The following is a description of a gene set: The genome of vertebrates contains endogenous retroviruses (ERVs) that have resulted from ancestral infections by exogenous retroviruses. ERVs are germline encoded, transmitted in a Mendelian fashion and account for about 8% of the human and 9.9% of the murine genome, respectively1, 2. By spontaneous activation and reintegration ERVs may cause insertional mutagenesis and thus participate in the process of malignant transformation or progression of tumor growth3, 4. However, if the innate immune system is able to recognize and control ERVs has not yet been elucidated. Here we report that, in vitro, nucleic-acid sensing TLRs on dendritic cells are activated by retroviral RNA and DNA from infected cells in vitro. Infection of TLR competent wild type mice with murine leukemia virus (MuLV)-like ERV isolates results in non-canonical gene upregulation, independent of type I IFN. In vivo, TLR3, -7 and -9 triple deficient mice (TLR379-/-) and mice with non functional TLR3, 7 and 9 signaling due to a mutation in UNC93B develop spontaneous ERV-induced viremia. More importantly, in TLR379-/- mice ERV-induced viremia correlates with acute T cell lymphoblastic leukemia (T-ALL). Multiple independent TLR379-/- T cell leukemia lines produce infectious MuLV of endogenous origin. These cell lines display de novo retroviral integration into the Nup214 or Notch1 gene locus leading to gene dysregulation that is reminiscent of aberrant Nup214 and Notch1 expression in human T-ALLs5. Overall, our results demonstrate that in addition to their role in innate immune defense against exogenous pathogens, TLR3,-7, and -9 may be essential for the control of endogenous retroviral mediated T-cell lymphomagenesis. species: Homo sapiens Human Gene Set: GSE24671_CTRL_VS_SENDAI_VIRUS_INFECTED_MOUSE_SPLENOCYTES_DN from publication Yu P, Lübben W, Slomka H, Gebler J, Konert M, Cai C, Neubrandt L, Prazeres da Costa O, Paul S, Dehnert S, Döhne K, Thanisch M, Storsberg S, Wiegand L, Kaufmann A, Nain M, Quintanilla-Martinez L, Bettio S, Schnierle B, Kolesnikova L, Becker S, Schnare M, Bauer S (PMID 23142781) Genes down-regulated in splenocytes: control versus infected with Sendai virus., and this is the list of marker genes: RFX1, AHNAK, CASTOR1, PRRT1, SEC16A, IQGAP2, MIA3, FIRRE, ZNF292, USP48, DDX39B, MMP9, TRAF3, ZFR2, RABAC1, RNF167, SEC23IP, CPSF1, SLC7A11 (NCBI Gene Id 23657), NDUFS7, TXLNG, RABEP2, ARID5B, FBL, TMEM64, ICOS, PYGO2, BOD1L1, SLC38A1, MIB2, PRRC2C, GABBR1, MTFR1L, SLTM, MID1, TPCN1, APBB3, STK4, RAPGEF2, LMBR1L, BLTP1, SP4, UBTF, BCL11B (NCBI Gene Id 64919), ZNF692, NFIA, RGL2, ZBTB14, SLC9A1, ZC3H18, TRIM65, F2R, KIF21B (kinesin family member 21B), TK2, TNK2, HGH1, CAMTA2, L1CAM, TMEM131L, ZIC3, CLINT1, CLK2, RBM25, CAMK1D, AR, GIMAP6, METTL17, PDE1B, TRABD2B, DHX16, EPN1, ARHGAP31, KMT2C, SSBP4, CLIP1, EIF4G3, IDS, RPL12, TGFBR2, GALT, SRP68, SMARCA2, KMT2D, CIAO3 (cytosolic iron-sulfur assembly component 3), SPIN1, COQ2, MBP, RAB3A, DALRD3, PPP4R2, ZNF287, RAP1B, DEXI, NOLC1, UFL1, KCTD12, TAF4, ZBTB4, KHNYN, RNF44, NXF1, HSD17B8, STX16, PRR14, PIK3CD, UBL3, EXOSC1, PIGQ, TAOK1, LGALS8, RASSF5, ARHGDIB, CNOT6L, ENTPD5 (ectonucleoside triphosphate diphosphohydrolase 5 (inactive)), NSUN2, EPB41, ATP6AP1, DMTF1, SELENOT, TNRC6C, SNRNP70, WDR82, RAI1, SELENOP, C8orf82, MBOAT4, WAS, ZSWIM9 (zinc finger SWIM-type containing 9), MAN2C1, RNF166, PRRC2B, VPS13D, CDC42EP3, MAST3, SUN2, PITPNC1, PACS1 (NCBI Gene Id 55690), CBX7, GABPA (GA binding protein transcription factor subunit alpha), IKZF1, IL17RC, QTRT2, HIRA, ST3GAL6, CD53, PLCG1, RPS14, OGT, RNF187, ZBTB6, AZI2, SPSB3, NUFIP2, CHD3, WDR46, NECAP2, NFATC3, KDM3B, ARGLU1, UBQLN1, ENTREP3 (NCBI Gene Id 149536), PREX1, HEATR1, LPAR6, SCP2, FUT8, PARK7, ZNF574, PHF1, FILIP1L (NCBI Gene Id 11259), ITGAL, VPS28, EIF1AD, FAM32A (family with sequence similarity 32 member A), SNAPC4 (NCBI Gene Id 80189), PTPN18, NIN, PCNX3, NCOR1, NUP210, RALGPS2, H6PD, TGFBRAP1, RUFY2, RNF38, ABHD8, THY1, SNX17, TNFRSF1A, TMEM52, SHISA5, CTSW, TECPR1, PRKACB, STX4, MAF, SLC9A9, ZNF148, ORAI2